Given this list of marker genes ANKRD11, TBX1, GTF2IRD2, GATA2, SPEF2, MS4A1, CCDC39, DNAH5, ZMYND10, AHDC1, RSPH1, NFKB1 (nuclear factor kappa B subunit 1), LRRC56 (leucine rich repeat containing 56), RSPH4A, ARVCF, TP63, APC2, SPAG1, HYDIN, WAS, DNAJB13, TGDS, TNFSF12, NME5, UFD1, STAT3, ICOS, SLC25A12, DNAAF6 (NCBI Gene Id 139212), CPLX1, GTF2I, DNAI2, CD79B, SEC24C, PIK3R1, PRTN3, SULT2B1, ROR2, NEK10, KMT2D, CYP4F22, TCF3, METTL27, IRF2BP2, BUD23, CFAP300, HIRA, DNAH11, HLA-DPB1, CFAP45, IRF6, COMT, NIPAL4, CTLA4, PIGH, STX1A, IGHM, DNAH1, CCNO, SLC39A7, ODAD3, BMP4, TGM1, TBX4, CFAP298, RSPH3, CD19, VPS37D, CFAP221, NECTIN1, OCRL, LIPN, TP73, DNAAF11, AK2, CR2, SDR9C7, IL11RA, DNAI1, LETM1, HLA-DPA1, ALOXE3, PTPN22, AGA, DNAL1, FGFR2, RREB1, DNAAF3, ALOX12B, ODAD2, NCF1 (NCBI Gene Id 653844), TNFRSF13B, NSD2, GP1BB (NCBI Gene Id 89199), DNAAF1, ABCA12, MSX1, RPGR, ODAD1, OFD1, CD79A, NME8, LIMK1, PIGG, GTF2IRD1, WIPF1, CD81, SHARPIN, GNB2, TTC12, DNAJC30, NXN, IGLL1, SPI1, CTBP1, DOCK8, ODAD4, DNAAF5, FKBP6, RSPH9, ELN, DNAAF4 (NCBI Gene Id 1867), KDM6A, KAT6A, TBL2, TNFRSF13C, GAS2L2, JMJD1C, DRC1, TAF1, BLNK, RUNX2, TAP1, STK36, RAI1, NELFA, CCDC40, CARMIL2, DNAH9, FOXJ1, FMR1, BAZ1B, NSD1, CLIP2, DNAAF2, BTK, RFC2, NFKB2, ASPRV1, MCIDAS, TMEM270, EIF4H, PGM3, CFAP74, LRRC8A, FOXN1, here is a description of the gene set: species: Homo sapiens Chronic otitis media Human Gene Set: HP_CHRONIC_OTITIS_MEDIA Chronic otitis media refers to fluid, swelling, or infection of the middle ear that does not heal and may cause permanent damage to the ear.